The following is a description of a gene set: Neighborhood of MAP2K3 Human Gene Set: GNF2_MAP2K3 species: Homo sapiens Neighborhood of MAP2K3 mitogen-activated protein kinase kinase 3 in the GNF2 expression compendium, and this is the list of marker genes: FOXO3, CTSE, KAT2B, EPB42, TOP1, BLVRB, UBAC1, CA1, RBM38, MARCHF8, TRIM10, MKRN1, GYPC (glycophorin C (Gerbich blood group)), ANK1, RANBP10, FBXO9, H4C3, TFDP1, SPTB, CDC27, RCL1, SLC4A1, NARF, NUDT4, GYPA, RHCE, SLC12A3, ALAS2, BNIP3L, PNP, USP15, AHSP, SNCA, XK, SELENBP1, OSBP2, DCAF11, PSMD9, HMBS, GLRX5, TMCC2, CROCCP2, TSPO2, RPIA, NCOA4, MPP1, FECH, RAD23A, NFE2, GYPB, EIF2AK1, CA2, RHD (NCBI Gene Id 6007), UROD, EIF1AY, CLIC2, FBXO7, MAP2K3, BSG, RHAG, H1-0, PPOX, ALAD, TRAK2, KLF1, XPO7, TAL1, ERMAP, HBQ1, MARK3, SLC22A4, GYPE, CAT, SPTA1, HDGF